Given this list of marker genes DPM3, SLC44A2, GALR2, PLCB3 (NCBI Gene Id 5331), DPM2, SLC44A3, LPIN1, SYNJ1, OCRL, OC90 (otoconin 90), LPCAT4, PIK3CD, ENPP6, TPTE2, DDHD1, PIGK, PLA2G2A, PCYT1B, PIK3CG, PTEN, PIP4K2A, INPP5K, ATG14, PON1, PLA2G4D, PIK3R1, DGKK, PIGV, PITPNM3, PIK3C3, FABP5, PI4KAP2 (phosphatidylinositol 4-kinase alpha pseudogene 2), PNPLA7, PLA2G5, ACP6, SMPD4, SLC44A1, PGP, OSBPL8, CHAT, PIP4P2, PIK3CB, NAAA, MTM1, PIGN, INPP5B, LDLR, PGS1, PLB1, NR1H2, ITPKB, PLAAT2, SLC44A4, APOA2, THEM5, SPATA18, NR1H3, PIGX, FABP3, ALOX15, PLA2G4F, PLCL1 (NCBI Gene Id 5334), SERINC1, SLC44A5, GPAT4, GPCPD1, PIGP, PGAP2, IPMK, PI4K2A, PCYT2, ABHD5, PTPRQ, GPAA1, PLA2G15, PIGU, PLA2G2E, LIPC (lipase C, hepatic type), PDGFA, PLCG1, PIK3C2A, DGKQ, PLCL2, PLA2G1B, MTMR12, MFSD2A, LIPH, PLD1, ABHD3, PLAAT1, PIP5K1A, PIK3C2B, PLAAT3, MBOAT1 (membrane bound O-acyltransferase domain containing 1), BPNT1, PIK3C2G, PLA2G6, MECP2, LCAT, PCYT1A, SH3GLB1, SLC30A5 (NCBI Gene Id 79021), MTMR9, PIGM, PLA2G2F, MBOAT2, PLA2G10, PIPSL, TTC7B, PIGY, AGPAT3, PIGB, DBI, PITPNM2, TMEM150A, SCARB1, PLSCR1, ENPP2 (ectonucleotide pyrophosphatase/phosphodiesterase 2), TAMM41, INPP5J, PNPLA8, DGKH, ABCA3, CWH43, PITPNM1, HYCC1, PIP5K1B (phosphatidylinositol-4-phosphate 5-kinase type 1 beta), PIGO, PAFAH1B1, PLCE1, UVRAG, PI4KA, PRDX6, BMX, SELENOI, GDPD3, AJUBA, DGKI, PIGT, PLAAT4, SERAC1, HTR2B, PLA2G7, PGAP4, ABHD4, PIGG, LPCAT2 (lysophosphatidylcholine acyltransferase 2), IMPA2, PLA1A, ABHD8 (NCBI Gene Id 79575), HADHA, SACM1L, SH3YL1, HDHD5, MTMR11, AGPAT1, APOC1, PISD, CHKA, IP6K3, CDS2, GDE1, SERINC5, SERINC2 (serine incorporator 2), DGKZ, INPP5F, PIGS, PIK3CA, PI4K2B, PLA2G2C, PIGA, DGKD, INPP5E, CHPT1, ABHD6, PIK3R5, TMEM86B, PIK3R3, FIG4, MTMR14, PLA2G2D, PLCH1, PGAP1, MTMR3, PLA2G3, CDS1, LCLAT1, EFR3A (EFR3 homolog A), CETP, OSBPL10, PIP4P1, LPGAT1, IMPA1, NR1H4, PIGQ, INPP1, OSBPL5, TAFAZZIN, ETNK2, MTMR7, MTMR2, MTMR8, GPAM, PIGF (NCBI Gene Id 5281), MTMR4, HTR2A, SMG1 (NCBI Gene Id 23049), PLCB4 (NCBI Gene Id 5332), HYCC2, PIGZ, PLCD1, IP6K2, PLA2G4E, INPP4B, DGKB, PTDSS2, PIKFYVE, GPLD1, PIGH, LPCAT1, CHRM5 (NCBI Gene Id 1133), VAC14, INPPL1, LIPI, TNFAIP8L3, PLA2G4C, PTPMT1, PLCG2, PLA2G4B, DGKA, ACSL3, PIGC, GPAT2, GDPD1, PLAAT5, PNPLA3 (NCBI Gene Id 80339), ITPKA, BPNT2, SYNJ2, CLN3, PIGL, CRLS1, PIP5K1C, APOA1, ATM, AGPAT4, DPM1, PIP4K2B, MTMR10, HTR2C, PLCH2 (phospholipase C eta 2), CEPT1, INPP5D, MTMR1, ITPKC, FAR1, IP6K1, PLD2, PLA2G4A, CDIPT, PNLIPRP2, ETNK1, ABHD16B, PEMT, DGKG, INPP5A, PLCB1, PDGFB, PIK3R4, LPCAT3, PIP4K2C, CHKB, AGPAT5, PTDSS1, GPAT3, ABHD16A, PIP5KL1, ABHD12B, ABHD12, PIGW, CAPN2, PHB2, PNPLA6, GNPAT, BECN1, EFR3B, MTMR6, PLCB2, AGPAT2, INPP4A, MBOAT7, PGAP3, PI4KB, NAPEPLD, DGKE, DNAJC19, TTC7A, MPPE1, APOA4, RAB38, here is a description of the gene set: Human Gene Set: GOBP_GLYCEROPHOSPHOLIPID_METABOLIC_PROCESS The chemical reactions and pathways involving glycerophospholipids, any derivative of glycerophosphate that contains at least one O-acyl, O-alkyl, or O-alkenyl group attached to the glycerol residue. studied in species Homo sapiens